Given this list of marker genes Nqo1, Coq2, Adh4, Ubiad1, Coq8b, Rtn4ip1, Coq4 (coenzyme Q4), Adck2, Ndufa9, Coq5, Pptc7, Coq9, Aifm2, Coq6 (coenzyme Q6 monooxygenase), Coq3, Pdss1, Hmgcr, Coq8a, Nqo2, Pdss2, Coq7, here is a description of the gene set: Mouse Gene Set: GOBP_QUINONE_METABOLIC_PROCESS The chemical reactions and pathways involving quinone. studied in species Mus musculus